The following is a description of a gene set: DNA microarrays can be used to identify gene expression changes characteristic of human disease. This is challenging, however, when relevant differences are subtle at the level of individual genes. We introduce an analytical strategy, Gene Set Enrichment Analysis, designed to detect modest but coordinate changes in the expression of groups of functionally related genes. Using this approach, we identify a set of genes involved in oxidative phosphorylation whose expression is coordinately decreased in human diabetic muscle. Expression of these genes is high at sites of insulin-mediated glucose disposal, activated by PGC-1alpha and correlated with total-body aerobic capacity. Our results associate this gene set with clinically important variation in human metabolism and illustrate the value of pathway relationships in the analysis of genomic profiling experiments. Human Gene Set: MOOTHA_ROS studied in species Homo sapiens from publication Mootha VK, Lindgren CM, Eriksson KF, Subramanian A, Sihag S, Lehar J, Puigserver P, Carlsson E, Ridderstråle M, Laurila E, Houstis N, Daly MJ, Patterson N, Mesirov JP, Golub TR, Tamayo P, Spiegelman B, Lander ES, Hirschhorn JN, Altshuler D, Groop LC (PMID 12808457) Reactive oxidative species (ROS) genes; based on literature and sequence annotation resources and converted to Affymetrix HG-U133A probe sets., and this is the list of marker genes: GPX4, ZNF33B, RHOA (NCBI Gene Id 387), SBNO2, PRDX3, PRDX6, SOD2